The following is a description of a gene set: from publication Yevshin I, Sharipov R, Kolmykov S, Kondrakhin Y, Kolpakov F (PMID 30445619) studied in species Mus musculus Mouse Gene Set: ZFP810_TARGET_GENES, and this is the list of marker genes: Rasl2-9, Tfrc, Kdm5a, Rex1bd (NCBI Gene Id 66462), Timm13, Gm25855, Nadsyn1, Shmt1, Carnmt1, D330041H03Rik, Bltp2, Magt1, Mapk1, Cep95, Vkorc1, Mir290a, Mdh1, Snora17, Ino80d, Gm22489, Brf1, Ralgds, Rsrc2, Fhip2b, Mir7b (microRNA 7b), Eif3d, Rrn3, Gtf3c6, Kank3, Ptf1aos, 2610005L07Rik, Gm16096, Slc25a40, Ppp6c, Gm4285, Clptm1, Ccdc159, Zc3h18, Ebf2, Pih1d1, Lck, Yars1, P4ha1, Gm7285, Fzd10, 1700008O03Rik, Ubr7 (ubiquitin protein ligase E3 component n-recognin 7 (putative), NCBI Gene Id 66622), Gdpd1, Fcnaos, Rpl22l1, Srsf1, Zbtb11, Zfp809 (NCBI Gene Id 235047), Bend5, Nlk, Wdr43, Leprot, Stx1a, Tssc4 (NCBI Gene Id 56844), Setd5, Tomm34, Ercc6l, Tcf25, Cacna1a, Zfp292, Pin4, Grb10, Abtb3, Gm26885, Cnnm4, 2410002F23Rik, Tbc1d10b, Ndufab1, Alkbh7, Ing4, Gm26725, Gt(ROSA)26Sor, Hspa8, Taf1d, Tfdp1, Tns1, Zfp623, Kcnf1, Lrba, Trip12, Magi1, Rgmb, Mthfd2, Btbd19, Prpf19, Eno1, Cdpf1, Tbc1d16, Map4k4, Dgke, Jak1, Hrh3, Pierce2, Cyb5r4, Usb1 (U6 snRNA biogenesis 1), Socs1, Kctd17, Stk32c, Prpf38a, Atp5mc3, Zcchc14, Dcakd, Eml6, Mphosph8, Ncoa4, Nudt1, Gprin1, Rnf216, Atp5f1a, Platr22, Fam162a, Pde4d, Foxm1, Gm2a, Pds5a, Tmem64, Cfl2, Bcas3, Chsy1, Ap3m1, Dmkn, Poc1a, Dus2, Pbrm1, Fndc3b, Celf1, Ubl3, Caprin2, Clasp1, Eef1a2, Calm3, Gm24452, Imp3, Sp1, Kntc1, Atp5f1b, Barhl1, Ddx5, Gse1, Eddm13, Akap1, Gli2, Ogt, Ranbp17, 1810062G17Rik, Marchf3, Eif2b4, Cd9, Mzf1, 1110002J07Rik, Usp46, 2410006H16Rik, Smap2, Prrc2c, Rere, Hexim2, Tsc22d4, H2-M5, Zbtb7a, Eif5a, Scmh1, Mir7668, 4933408N05Rik (NCBI Gene Id 71122), Rfx3, Uso1 (USO1 vesicle docking factor), Asrgl1, Slc39a3, Scrt1, Tjp2, Samd10, 4931406C07Rik (RIKEN cDNA 4931406C07 gene), Gnl3, Fbll1, S100pbp, Gm4349, Satb2, Nfxl1, Ptbp1, Hsp90ab1, Spats1, Aco2, Crebrf, Qtrt2, Snord52 (NCBI Gene Id 100217427), Gm28047, Kbtbd3 (NCBI Gene Id 69149), Tmem177, Gm26330, Dhcr7, Ube4b, Vamp4, Gpn3, Xpo1, Tent2, Ammecr1 (NCBI Gene Id 76140), Tmem175, Adk, Atp5mg, Snora24, Tfap4, Tmem116, Usp24 (ubiquitin specific peptidase 24), Lyl1, Fignl1, Slc35b2 (NCBI Gene Id 73836), Lrrc27, Ccdc92, Mtmr12, Ino80dos, Phf5a, Pdk1, Spsb1 (splA/ryanodine receptor domain and SOCS box containing 1), Epg5 (NCBI Gene Id 71423), Phf12, Hmgb1, Sinhcaf, Ccpg1, 4930481B07Rik, Cpne9, Fkbp5, Nktr, Orc2, Ldhb, Gas5, Nr1d2, Gmfg, Katnb1, Gm10010, Fip1l1, Gm26247, Map3k3, Aasdhppt, Pnrc2, Rnf170, Snx17, Rab3gap2, Fzd10os, Cacnb3, Mrm2, Mob4, Tatdn2, Chtf8, Gm25894, Styxl1, Tnrc6a, Asic3, Cops7a, Gpr19, Hk1os, Tmsb4x, P2rx3, Polr2e, Rfwd3, Rora, Ipo13, Pprc1, Gls2 (NCBI Gene Id 216456), Gm24296, Nop58, Rnf13, Plcl2, Fam174c, Nnt (nicotinamide nucleotide transhydrogenase), Ppp1r13b, Sptan1, Zfp319, Esrra (estrogen related receptor, alpha), Glra1, C330024D21Rik, Bola2, Atg16l1, Ccdc191, Cherp, Psmb6, Slc35b1, Smg7, Hook3 (hook microtubule tethering protein 3), Tdrd3, Mdc1, Fry, Osbpl8, Zfp146, Cacng3, Ywhaz, Foxd2os, Gm14966, Bard1, Akap8, Mgst2, Eef1a1, Aqp3, Gm11655, Cbr1, Cbfb, Gamt, Etv4, Mapt, Fbxo36, Zfp27, Kcnt2, Rbm7, Zfp664, Ctnnd1, Prpf3, Olig3, Snord49b (small nucleolar RNA, C/D box 49B), Mir8098, Plin1, Erp29, Mfge8, Slc3a2, Mdk, Stx3, Flad1, Anapc10, Tll1 (tolloid-like), Caskin2, Tpt1, Nipbl, Tram1, Zbtb37, Pcmtd1, Nol4, Rraga, Gm26224, Cacng2, Nfe2l1 (nuclear factor, erythroid derived 2,-like 1), Cnot6, Anxa5, Slc6a7, Med18, Spcs1, Ap1b1, Gm15704, Dnajc13, Kpna2, Sergef, Cradd, N4bp2l2, Fbxw7, Gm22357 (predicted gene, 22357), Mrpl14, Pbx4, Abce1, Fbxo15, Baz1a, Arl2bp, Fbxo9, Gtf3c3, Usp1, Ccdc40, Dicer1, Ociad1, Tdp1, Frat1, Mospd3, Efcab11, Gm5617, Ywhag, Mapk8ip2, Rbm47, Tm2d2, Rps8, Orc1, Snord55, Lrrc49, Mir8090, Tex14, Sf1, Os9, Ralgapb, Mlxip, Sec24c, Mir7009, Gm32950, Adam9, Brms1, Rprd2, Rassf8 (Ras association (RalGDS/AF-6) domain family (N-terminal) member 8), Atg2a (autophagy related 2A), Zfp687, 1110038B12Rik, Hes1, Mpv17l, Wdpcp, Bcas2, 2210417A02Rik, Raf1, A630072M18Rik, Zfp36l1 (NCBI Gene Id 78714), Asxl1, Zfp865, Bcl2l1, Recql, H3c11, Snhg8, Gtf2ird1, Snhg7os, Rerg, Rad51c, Trim37, Klhdc10, Tmem198b, Ube2m, Lars1, Arhgap26, Tbx3, Magi3, Mkks, Gak, 2500004C02Rik, Cfap44, Mbtps2, Tsen54, Atf7, Wdfy2, Neurod4, Hvcn1, Psma3, Fam216a, Slc9a8, C030034I22Rik, Ppif, Ash2l, Utp25, Cfap418, Utp4, Mdh2, Spry4, Omg, Slx4ip, Foxd2